Given this list of marker genes Pea15a (NCBI Gene Id 18611), Sgpl1, Raf1, Ints4, Pam, Mfsd9, Naa60, Pex5, Map1lc3a, Cyth1, Trappc10, Nsf, 5031439G07Rik, Rnf185, Txndc5, Tmem127, Ube2v1, Mia2, Gns, Cebpa, Acsl6, Rnf4, Sbf2, Gna12, Cyp2b9, Snx27, Ttc7, Ap1s3, here is a description of the gene set: Genes up-regulated in Harderian gland tissue upon knockout of AOX4. Mouse Gene Set: TERAO_AOX4_TARGETS_HG_UP studied in species Mus musculus The mouse aldehyde oxidase AOH2 (aldehyde oxidase homolog 2) is a molybdoflavoenzyme. Harderian glands are the richest source of AOH2, although the protein is detectable also in sebaceous glands, epidermis, and other keratinized epithelia. The levels of AOH2 in the Harderian gland and skin are controlled by genetic background, being maximal in CD1 and C57BL/6 and minimal in DBA/2, CBA, and 129/Sv strains. Testosterone is a negative regulator of AOH2 in Harderian glands. Purified AOH2 oxidizes retinaldehyde into retinoic acid, while it is devoid of pyridoxal-oxidizing activity. Aoh2(-/-) mice, the first aldehyde oxidase knockout animals ever generated, are viable and fertile. The data obtained for this knockout model indicate a significant role of AOH2 in the local synthesis and biodisposition of endogenous retinoids in the Harderian gland and skin. The Harderian gland's transcriptome of knockout mice demonstrates overall downregulation of direct retinoid-dependent genes as well as perturbations in pathways controlling lipid homeostasis and cellular secretion, particularly in sexually immature animals. The skin of knockout mice is characterized by thickening of the epidermis in basal conditions and after UV light exposure. This has correlates in the corresponding transcriptome, which shows enrichment and overall upregulation of genes involved in hypertrophic responses. from publication Terao M, Kurosaki M, Barzago MM, Fratelli M, Bagnati R, Bastone A, Giudice C, Scanziani E, Mancuso A, Tiveron C, Garattini E (PMID 18981221)